The following is a description of a gene set: Pathway Definition from KEGG: RPA == RAD17+9-1-1 == TOPBP1 == ATR+ATRIP -> CHEK1 Human Gene Set: KEGG_MEDICUS_REFERENCE_ATR_SIGNALING studied in species Homo sapiens ATR signaling. Pathway ID: N01451. Pathway type: Reference. Pathway class: nt06506 Double-strand break repair., and this is the list of marker genes: ATRIP, CHEK1, RAD17, RPA4, ATR, RPA2, RPA3 (NCBI Gene Id 6119), RAD9A (NCBI Gene Id 5883), RAD1, RPA1, TOPBP1, HUS1